Given this list of marker genes B3GNT2, B3GNT3, ST3GAL1, PRELP, ST3GAL4, GLB1L3, CHST2, B4GALT4, GLB1L2, B4GALT6, B3GNT7, CHST1, HEXA, CHST6, GALNS, FMOD, B4GALT1, ST3GAL3, SLC35D2, ST3GAL6 (NCBI Gene Id 10402), GLB1L, B3GNT4, HEXB, OMD, KERA, LUM, B4GAT1, GLB1, OGN, B4GALT3, ST3GAL2, GNS, ACAN, CHST5, B4GALT5, B4GALT2, here is a description of the gene set: species: Homo sapiens Keratan sulfate/keratin metabolism Human Gene Set: REACTOME_KERATAN_SULFATE_KERATIN_METABOLISM